The following is a description of a gene set: Binding to a S100 protein. S100 is a small calcium and zinc binding protein produced in astrocytes that is implicated in Alzheimer's disease, Down Syndrome and ALS. Mouse Gene Set: GOMF_S100_PROTEIN_BINDING species: Mus musculus, and this is the list of marker genes: Anxa2, Cacybp, Ahnak, Atp2a2, S100b, Iqgap1, Anxa11, Ager, S100a11, S100a11-ps, S100a6, Ezr, S100a1, Fgf1, Kcnk3